Given this list of marker genes TUBB6, SUFU, UBA1, PANK2, PLCH1 (phospholipase C eta 1), TMEM218, IFT80, FBN1, FARS2, TANGO2, PURA, WFS1, RHBDF2, TK2, SPRED2, SLC5A7, SPEN, KCNK9, HESX1, NADK2, DISP1, AASS, TCTN1, PEX10, AQP2, TRAPPC12, SCO1, NAA20, EPB41L1, C2CD3, AAAS, TRAF3IP2, KRT5, FLNA, GP1BB, COMT, WWOX, GSX2, PEX19, ERCC2, SYNGAP1, TG, CHD8 (chromodomain helicase DNA binding protein 8), PEX2, GTPBP3, KIAA0586, RPGRIP1L, WDR19, SUPT16H, SYNE1, PIGU, TSFM (Ts translation elongation factor, mitochondrial), ARL3, CLTCL1 (clathrin heavy chain like 1), FKTN, PEX26, B9D1, RNF6, COX8A, SCNN1B, TSEN2, CHRNA1, TTC21B, SRP54, CASZ1, TFG (trafficking from ER to golgi regulator), COX16, TSEN34, SUZ12, OCRL, MTHFR, PGAP3, DHCR7, CDH1 (cadherin 1), STIL, PIGO, ITGA7, TXNL4A, GOT2, CYP11B2, PIGV, CCDC22, DUOX2, INPP5E, TBCK, NUDT2, SATB2 (SATB homeobox 2), TBC1D20, IFT74, RYR1, VAMP1, FLCN, OTUD5, PEX1, B3GALT6, SCN2A, PEX3, TPM3, TSPYL1, HDAC8, SEMA3E, PDHA1, PNPT1, UBE4B, TP63, SIK1, STAG2, TMEM231, CLCN6, CDON, USP7, ERCC1, NRAS, PRKCZ, ARSA, LUZP1, AFF4, ODC1, ATAD3A, PWRN1, UQCRC2, TGIF1, KAT8, AVPR2, ASXL2, BCOR, SLC18A3, TMEM67, EZH2, CRIPTO, IVD, SEC24C (SEC24 homolog C, COPII coat complex component), COL1A1, POLR3K, PEX13, KDM6A, TSHR, FGFR2, TAF6, MAGEL2, FGFR1, TMEM216, TGFB1, DYNC2LI1, DLG1, OTC, HIRA, TBC1D24, DLL1, MSX1, PLXND1, HERC2, ALS2, EIF5A, UFD1, GMPPA (GDP-mannose pyrophosphorylase A), ERCC5, CASR, NAPB, LONP1, TRIP4, PIEZO2, GBA1, SPG11, NDUFAF8, TPM2, KCNA1, SLC9A6, PTPN23, SCN1B, COLQ, SMARCD1, NDN, MPV17, DEGS1, MTRFR, ATP6V1B2, SNORD116-1, TCTN2, ARV1, AUTS2, POLR1B, KMT2D, DCHS1 (dachsous cadherin-related 1), MKS1 (NCBI Gene Id 54903), NSD1, DLX4, WASHC5, PRUNE1, IYD, DDX3X, PARS2 (NCBI Gene Id 91517), VPS13B, TRAPPC11, B3GLCT, POLR1D, RAC1, TSEN15, RREB1, ZIC2, KCNAB2, ECHS1, PTPN11, MCCC1, KIF15, PIBF1, RPS6KA3, HTRA2, AFG2A, GRM7, KANSL1, SLC5A5, PLAG1, TOGARAM1, POLR1C, GNB2, SDHA, PCCA, MMACHC, LHX3, CDKL5, CLEC7A, DST, TSEN54, MYH3, PTCH1, CNOT2, CBL, PIGT, PAX8, TPO, ERCC8, OFD1, ALG14, CAMLG, IKBKG, DYNC2I2, ELN (NCBI Gene Id 2006), BRD4, GPT2, CREBBP, RPL10, FLI1, GRHL3, SYT2, PRKCSH, KRT14, LAMA2, GAS1, NIPBL, NFKBIA, UBE3B, EN1, PEX16, SETBP1, KIF7, NFIX, YY1, PIGL, LAMB2, RTL1, SEPSECS, ARMC9, LIG4, SLC25A19, BUB1B, SELENON (NCBI Gene Id 7800), TBX1, HACD1, DMPK, DYNC2I1, SCN9A, SOX11, SOS1, DUOXA2, MECP2, CBY1, IFT172, MKRN3, ATP10A, ADNP, PRDX1, ITCH, CTCF, EPG5, TET3, UGP2, RAD21, ARVCF, ACTA1, SPTLC1, MGAT2, CPT2, DPM1, PDGFRA, MMAA, TRAPPC4, SMARCC2, HRAS, PSAP, CPLANE1, TRMT10C (NCBI Gene Id 54931), PMM2, PCCB, SNAP25, ASXL1, GNPTAB, CHD7, PROP1, PQBP1, GLRA2, RRAS, POLR1A, HSPD1, MYT1L, ZNHIT3, KIF5A, FOXP1, PEX14, PGAP2, PHIP, PDE10A, GCSH, MRPS16, HSD17B4, GAA, PDE6D, LARGE1, CHRNE, KIAA0753, BRAF, UBB, FAT4, ARID1A, BLM, ARX, VPS35L, RAB3GAP1, ARID1B, PPP1CB, GRIN1, TIMM22, COL13A1, UBTF, EP300 (NCBI Gene Id 2033), BIN1, PDPN, DPYD, ZFX, BCS1L, NLRC4, IRF6, CHAT, MYO1H, SCYL2, HSPG2, SH3BP2, FAM149B1, GFM2, HNRNPK, TUBB3, PGAP1 (NCBI Gene Id 80055), PCGF2, TALDO1, SLC6A8, RASA2, NDUFS4, DYNC2H1, FARSA, DLEC1, SPOP, ZMIZ1, PNKP, UBE3A, SLC32A1, RETREG1, CLN8, SDHD, POU1F1, CNTN1, FOXP2, PWAR1, SOS2, MLXIPL, DALRD3, PNPO, SIN3A, B9D2, ARHGAP29, SAMHD1, ASXL3, LZTR1, UNC45B, TCEAL1, PHF6, ACTL6B, CEP104, COG5, COBLL1, PEX5, SCNN1G, CSPP1, NODAL, CDK8, SDHB, CLDN16, TRMU, PIGN, RRAS2, CNOT3 (NCBI Gene Id 9756), ZNF699, HADH, LRP5, TREX1, MAP2K1, ERCC6, PIGY, YIF1B, LYRM4, NUP214, MED12L, PEX12, WNK1, PPP1R21, DMXL2, COX10, MOCS1, IDH1, ASL, SNRPN, PLAA (NCBI Gene Id 9373), SIM1, NACC1, GLI2, MYL2, BMP4, SLC46A1, MAP3K7, HMGA2, EIF4A2, OCA2, MID1, SLC25A1, SKI, DGUOK, IL17RA, UGDH, FDFT1, MT-TE, SNORD115-1, CEP120, IFT140, NRCAM, SIX3, MT-TL1 (NCBI Gene Id 4567), MAP3K20, HADHB, MMAB, LIFR, CRLF1 (cytokine receptor like factor 1), SDHAF1, AHI1, UNC80, ATP7A, PEX6, SCNN1A, FKRP, GNAO1, DEAF1, POGZ, FGF8, PRDM16, MEG3, RNF2, TIMMDC1, SCN4A, MYO9A, KRAS, BTD, TRIO (NCBI Gene Id 7204), KMT5B, IL17F, IGF2, TOR1A, RAPSN, UQCRFS1, SUCLA2, FOXH1, ACTN2, CHRND, RIC1, TGFBR2, RAB3GAP2, CHRNB1, LRPPRC, SPTBN4, NECTIN1, KLHL40, HLCS, FLII, RAI1, DDC, ST3GAL5, CDKN1C, PPP2R1A, COL6A1, NDUFS8, NALCN, PRPS1, KDM3B, COL7A1, TOPORS, GRB10, SCN3A, RAF1, CCDC32, POMT2, ARHGEF38, ALG12, SMC1A, ELP1, PIGP, ATP6V0A2, TSHB, NSUN2, PUF60, RNF13, SLC16A2, MOGS, SMPD1, ORC1 (NCBI Gene Id 4998), WDR26, TAF4, MAP2K2, CASK, DYRK1A, SMC3, H19, AGRN, EMG1, TOP3A, CARS1, ASPA, EDEM3, HADHA (NCBI Gene Id 3030), PIGQ, VRK1, KIF1A, RIT1, CC2D2A, SLC5A6, COG1, SPTBN1, LHX4, NPAP1, SMARCB1, SLC25A22, ARL13B, DNM1L, IL17RC, GCH1, ATP6V0A1, SLC1A4, RALGAPA1, TCTN3, BCKDHA, JMJD1C, TMEM237, DCX, DLK1, CEP41, PEX11B, IQSEC2, SCN1A, DPYSL5, MRAS, SOX9 (NCBI Gene Id 6662), POMT1 (NCBI Gene Id 10585), GALC, GGPS1, PIGW, KATNIP, PSAT1, AIFM1, CLCN1, CISD2, SON, COL2A1, RARS2, TCOF1, EFTUD2 (NCBI Gene Id 9343), MMP23B, REV3L, HYLS1, FUS, SLC52A1 (solute carrier family 52 member 1), ATPAF2, TRIM8, SIGMAR1, GABRD, TXN2, ATRX, SEC63, MTM1, RERE, SHH, NEUROD2, NONO, PTS, OPA1, here is a description of the gene set: Impaired feeding performance of an infant as manifested by difficulties such as weak and ineffective sucking, brief bursts of sucking, and falling asleep during sucking. There may be difficulties with chewing or maintaining attention. Feeding difficulties in infancy Human Gene Set: HP_FEEDING_DIFFICULTIES_IN_INFANCY studied in species Homo sapiens